Given this list of marker genes ELOVL2, HSD17B4, PEX2, ACOX1, ACOX2, ELOVL7, CYP4F12, ACSBG1, HACD1, SLC27A2, ACSL6 (acyl-CoA synthetase long chain family member 6), ACOT4 (NCBI Gene Id 122970), ACAA1, ABCD1, ACSL1, ELOVL5, TECRL, ELOVL1, HACD3, ACOT1, ABCD2, PEX5, ACOT2, ELOVL3, TECR, SLC27A5, ABCD3, SLC27A4, ABCD4, CYP4F2, HACD4, ELOVL4, ELOVL6, SLC27A6, HACD2, here is a description of the gene set: The chemical reactions and pathways involving a very long-chain fatty acid. A very long-chain fatty acid has an aliphatic tail containing more than 22 carbons. studied in species Homo sapiens Human Gene Set: GOBP_VERY_LONG_CHAIN_FATTY_ACID_METABOLIC_PROCESS